Given this list of marker genes Obox4-ps29, Obox4-ps22, Ceacam13, Gm24708, Ceacam3, Obox4-ps33, Gm45219, Gm6065, Nop53, Ppp5c, Dhx34, Obox2, Ceacam12, Obox6, Pnma8a, Arhgap35, 4833404L02Rik, Psg16, Obox4-ps30, Pnma8c, Prkd2, Bbc3, Obox3, Tmem160, Obox4-ps19, Gm29725, Gm17981, Sae1, C5ar2, Ceacam15, Inafm1, 2700080J24Rik, Ass-ps1, Crx, Ceacam23, Obox3-ps6, Gm29443, 9330104G04Rik, Slc1a5, Snord23, Obox4-ps23, Pnma8b, Gm9521, Obox4-ps32, Kptn, Obox3-ps5, Ceacam14, Gm9519, Calm3, Obox4-ps21, Psg29, Gm5586, Obox4-ps18, Obox4-ps20, Gm24576, Gm5418, Ceacam-ps1, Strn4 (NCBI Gene Id 97387), Obox5, Obox4-ps28, Obox4-ps31, Hif3a, Ptgir (prostaglandin I receptor (IP)), Ccdc8, Obox4-ps24, Obox4-ps26, Gm8209, Gm26473, Zfp541, Ceacam9, Gm17826, Dact3, Psg-ps1, Ehd2, Gm32846, Gng8, Gm5322, Slc8a2, Igfl3, Meis3, Gm7287, Obox1, Selenow, Obox4-ps25, Obox4-ps27, Ceacam5, Fkrp, Gm32772, Bicra, Mrip-ps, Npas1, Ccdc9 (coiled-coil domain containing 9), Gm38948, Napa, Ceacam11, Zc3h4, Obox4-ps34, Obox4-ps35, Gm25815, Crxos, Ap2s1, C5ar1, here is a description of the gene set: species: Mus musculus Mouse Gene Set: chr7A2